Given this list of marker genes Lrp5 (low density lipoprotein receptor-related protein 5), Lrp6, Abcb1a, Ctnnb1, Ndp, Cldn5, Mfsd2a (NCBI Gene Id 76574), here is a description of the gene set: Mouse Gene Set: GOBP_ESTABLISHMENT_OF_BLOOD_RETINAL_BARRIER studied in species Mus musculus Establishment of the barrier between the blood and the retina. The blood-retinal barrier is located at two levels, forming an outer barrier in the retinal pigment epithelium and an inner barrier in the endothelial membrane of the retinal vessels. Both these membranes have tight junctions of the 'nonleaky' type.